Given this list of marker genes TMEM41B, SFXN1, SATB1, TCFL5, HTATIP2, RIT2, PTBP2 (NCBI Gene Id 58155), TSHZ2, SUCLA2, CDK14, SDHD, OGFRL1, GPR63, HLA-DPA1, SLC6A15, PTN, SMURF2, STXBP5L, ZNF665, COL13A1, MAP7D2, REPS2, GFM2, MORF4L1, CCDC89, MORF4L2, ARHGAP44, SPATA9, CIBAR1, ASPA, ALG6, CYB5R4, MAPK6, DNAJC6, GLYAT, PINK1, RWDD4, SLC22A10, ZGRF1, KITLG, NEDD1, EPHA5, NR1D2, DISC1, TTBK2, UBE2D3, ARL13B, NUDT4, SDHAF3, HNRNPC, REDIC1 (NCBI Gene Id 283461), ELOVL6, SKA2, KATNBL1, ITGAV, INPP5F, SPDL1, STAU2, BBC3 (NCBI Gene Id 27113), PDCD2, NLGN4Y, COPS6 (NCBI Gene Id 10980), ORC4, CACNB4, SCN3A, WASF3, C1orf105, ZNRF3, GCM2, PRDM4, PLCB4, here is a description of the gene set: from publication Chen Y, Wang X (PMID 31504780) Genes predicted to be targets of miRBase v22 microRNA hsa-miR-96-3p in miRDB v6.0 with MirTarget v4 prediction scores > 80 (high confidence targets). Human Gene Set: MIR96_3P studied in species Homo sapiens